Given this list of marker genes PPP2R5C (NCBI Gene Id 63377), MIR647, KTN1, ATP13A1, LINC01255, ERICH6B, ENY2, RN7SKP34, PCP4 (Purkinje cell protein 4), RNU6-1243P, CD163, EPSTI1, TNFRSF4, ENPP3, UFL1-AS1, STARD3, RPS28P1, ABHD13, KRTAP8-1, ISG15, HSPD1P7, LHPP, ZNF846, GTF2H4, SPATA7, MTCL1, MRPL48, ESPNP, NKTR, MRPL39, LINC01742, MS4A7, LINC01697, LRRN4, CYP4A27P, SNHG5, ZNFX1, BNIP3P5, SLC1A4, ELOVL1, HSPA14, ENSG00000277020 (NCBI Gene Id 105370103), TAF3, LIFR-AS1, ATP7B, FLOT1, CSPG5, CFAP61, ENSG00000260132, MAGED2, ADD1, CEP192-DT, COL15A1, MT-TE, FAM185BP, NPAT (nuclear protein, coactivator of histone transcription), RNU6ATAC34P, ZNF343, LINC01215, HABP2, CACYBPP3, SYNE2, RNA5SP29, POMGNT2, DYNLT1, SIMALR, NDUFB2-AS1, GPR137C, KANK1, TMEM123, LINC02633, TTC3, ABCD1, KCNMA1, RSPH3, PSG6, MAFTRR, EIF5A, TBRG1, SLC8B1, SCTR, RPSAP64, MT-TS2, KIZ, BTBD3, PSMA6P4, TPR, SYTL3, DAB2, MIR520B, P2RX1, PGAM3P (phosphoglycerate mutase 3, pseudogene), RPL38, RAB11FIP2 (NCBI Gene Id 22841), RNASEK-C17orf49, RB1-DT, PIK3R3, REPS1, LINC02593 (NCBI Gene Id 284598), FCF1, TTLL5, VASH1, SYT5, KIF4A, SOX6, KRTAP19-2, HES4, RUNX1, LINC01168, KCTD10, MHENCR, STRADB, ARMH1, UBAP2, TUBA1A, TEX30, FKTN-AS1, UNC79, PPP1R2P2, ICAM4, MADCAM1, MCM8-AS1, ZBED3-AS1, ATG3, ZNF225, LINC00554, EFCAB6-DT, RHOT2, ARSG, SEC23A, RHOBTB1, KEL, WDR91, USP17L18, RASSF2, INSIG1, ANAPC15, TRIM7-AS2, SPAG16-DT, KRTAP19-3, FBXL5, RANBP3, FAM217B, CENPBD1P (NCBI Gene Id 92806), ARID1B, CREB3L2, ALDH5A1, PPP1CC, SPOCD1, LINC00159, IGHV1-14, KDM1B, IFT52, ETS2-AS1, NDUFA6, TRAPPC1, CASP4, BTN2A3P, RNU6-836P, RNU6-782P, BRD2, GRAMD4, ENSG00000204684, MT-TN, MIR8075, MTND5P11, MTG2, MSMB, RALB, KRAS, LITAF, SLC35A5 (solute carrier family 35 member A5), MYOSLID-AS1, ARMC10 (armadillo repeat containing 10), LINC00865, AFDN, RWDD2B, CRYGN, DSCC1, ZNF821, EDRF1-AS1, BTF3L4, FRG1DP, MED15, PDZD11, ZC3HC1, ENSG00000260520, MYO18A, SLC7A5P2, HLCS-AS1, IKBKB-DT, FAM24B, LINC01080, SH3BGR, RTCA-AS1, C12orf75, KRTAP19-7, SH3KBP1, MTFR1, NIPSNAP1, TMEM263, RNU6-759P, RBFA, ZNF235, TRAK2, DDX39B, MAP3K7CL, SCARNA13, PRPF4, RBM11, SIDT1, CALM1, HIGD1AP14, MZB1, NPRL2, PARGP1, MRPS31P4, PPIAP11, STAT3, COX7C, AKAP7, PRCP, MIR3613, COX5AP1, ZBTB18, RBM12, MEG8, LCK, KIF26A-DT, KRTAP20-2, BID, WNT8A, GEMIN4, SLC20A2, REC8, ZCWPW1, LINC00654, RPL34, OXR1, RNF146, TMEM175, TAGAP-AS1, ARL2BPP3, HEY1, CLIC6, STRN3, OR10H5, GET1, AKR1D1, SPATS2L, NAPG, SPTAN1, ASPHD1, ATP2C2, TASP1, SETDB2, RALY, TPM2, ZNF732, KBTBD6-DT, AFG3L1P, CPT2, SAMD4B, GID8 (NCBI Gene Id 54994), SPATA2, VWA8-AS1, TBCD, NUP58, NIN, LIG1, RNA5SP21, NAE1, RTCA, MORC3, DLST, ZNF276, KAT6B, RPRD1B, TTC39A, ZSWIM9, MLEC, CUL5, VIP, HEXIM2-AS1, GNG10P1, GUCY1A1, CYP2F2P, CHMP3, SECISBP2, NHLRC3, EXD2, HBP1, GSTO2, LINC01522, ABCC9, ABCD4, LPIN3 (NCBI Gene Id 64900), THAP9, MRPL49, ZNF548, IPO5 (importin 5), DCAF5, WDR31, SNHG11, CEP295, ZSCAN25, ENSG00000267288, SAMTOR, THNSL1, LINC00189, SCN9A, EML3, LRR1, DDI2, EML1, LINC00658 (NCBI Gene Id 100507629), MAPK6P2, MRPS31P5, DAAM1, SLC35F5, TEX10, MS4A14, MGRN1, KDM5A, CPNE1, LYPD5, GLRX5, RORA-AS1, KIF13B (NCBI Gene Id 23303), CCT8, PPP1R3D, PAFAH2 (platelet activating factor acetylhydrolase 2), DCLRE1A, CIRBP, PIK3AP1, RNU6-8, LINC00710, PODN, ADAM28, MT-TP, ITIH5, AACS, ANKRD29, MARK1 (microtubule affinity regulating kinase 1), TTLL4, ZNF582-DT, MRPS17, HS6ST1, DSG1-AS1, WAC, KRTAP6-2, NUP153-AS1, ZBTB26, NUDT15 (nudix hydrolase 15), JPH4, PAIP1, ZC3H15, MRPS16P2, ZNF365, ANKRD66, PDE10A, KDM8, BRWD1, CALM3, ADISSP, ZFP69B (ZFP69 zinc finger protein B), RNU6-1257P, ARHGAP5-AS1, IFI27L1, RPS29, LATS1, FTO (NCBI Gene Id 79068), TMX4, ZNF460, GAS7, ACADL, RPL11, POU6F2-AS1, PAXBP1, WDTC1, ZNF256, SPINT1, ELP4, CCDC86, OBI1-AS1, ATXN8OS, TLR9, KCNH3, ARHGAP24, VPS16, RPL23AP12, RUBCNL, SEC13, TYMSOS, SULT1A1, IER3-AS1, PRM1, TTC3-AS1, LRRC8C-DT, POLB, TIAM1, MTRF1L, NOP14-AS1, COX20, ZNF155, LINC01134, LRRC63 (leucine rich repeat containing 63), RAC1P3, ZNF544, TONSL, LRRC8C, FEM1B, EIF5A2P1, SNORA71E, CYP46A1, DPP6, KCNK15-AS1, GNG2, SOD1, ASXL1, SEZ6L2, ZNF606, SUPT20H, DHRS4, ARNT, CORO1C, MIR7151, WARS1, METTL8, TYW1B, SON, NBPF1, CAMK2G, H2AZ1-DT, MTCO3P12, H4C16, ZFHX2-AS1, VPS13A-AS1, COA4, PPP4R3A, UQCRC2, STT3A, DHRS4-AS1, VPS13B-DT (NCBI Gene Id 124900254), ATP9A, H2AZP3, ANP32A (acidic nuclear phosphoprotein 32 family member A), MIR7111, AP4M1, LINC00921, RNY4P14, FGF14, CRYZL1, SSX2IP, ARF5, SATB1, POU6F2, HMGN1P5, WDFY2, SHISA2, H1-4, FUNDC2, WDFY4, BORCS7-ASMT, BACE2-IT1, RNF103-CHMP3, ZNF624, LINC02295, DENND6A-DT, FOS, ZNF121 (NCBI Gene Id 7675), RN7SL164P, KCNE1, C1orf174, CTR9, OLMALINC, MTA3P1, SPMIP4, SRC, SLC35F4, EIF4ENIF1 (eukaryotic translation initiation factor 4E nuclear import factor 1), KCNS1, TAF1, NARF-IT1, EFCAB14, SMARCA5, LDHAL6FP, KHDRBS2, SLC47A1, DR1, CUEDC1, PYM1, ENTPD1-AS1, ARID1A, SLFN12, SUB1, UNKL, CCDC146, VARS2, PTPRU, KRTAP19-10P, LINC01075, SETD4, PTRHD1, LEPROT, LSM14B, NUP210, C8orf74, MAP3K3, ARFGEF2 (NCBI Gene Id 10564), DNAH7, IFT88, NANOS3 (NCBI Gene Id 342977), CHD9, FBXL13, LINC00310, LST1, MT-TY, TRBV8-1, EPCIP, PIGG, GPR108, RAB30-DT, STAM2, LINC01624, SEPTIN7, PHLDB1, PRPF19-DT, CTSG, SMIM13, IFIT3, TMED5, TXNDC12, KDM1A, MOK, BAGE2, HERC3, LCP1, SHD, MYCBP2-AS1, CACNB2, SLC37A3, SFI1, LRCH1, ENKUR, GABPA, TRAM1 (NCBI Gene Id 23471), POLR1F, TMEM241, URB1-AS1, CLTA, ENSG00000179253, CNIH2, SRRD, DCHS2, LRAT, KRT26, ROM1, ATM, RPH3A, TCAF1, DNAJC3, ENPP2 (NCBI Gene Id 5168), SUSD4, VPS36, ABLIM1, APLF, LRRC61, DBT, TMEM272, CENPT, LINC01229, KIF18B, DDX50 (DExD-box helicase 50), AMZ2, SNHG31, PMS2CL, HTR5BP, ADIRF-AS1, ANAPC16, RAD51, TEX14, KAT14, TLDC2, F8, ERG, PLEKHG2, CDK5RAP3, TPMT, ZBED3, ZBTB17, LZTFL1, SERGEF, RNY3, EIF3FP1, CSNK1G2, COX4I1, ATP8A2P2, C11orf96, CNOT9, PHF8, CLEC14A, TADA2B, TMEM141, DUX4L16, DUSP5, AHI1, RNF214, RB1CC1, LRRCC1, DENND6A, LINC00299 (NCBI Gene Id 339789), PCBP1-AS1, ZGRF1, PWWP3A, SMURF2, PSMG1, HMGN1, LINC01607, MT-TH, GJE1, RNA5SP484, EXOSC8, ZNF101, ODR4, RAD1, ADCYAP1, DOP1B, CRLS1, IGHV7-34-1, SLC46A3, LINC00431, TNKS2-DT, PA2G4, MT-ND6, ZC3H14, VAC14, CCDC83 (NCBI Gene Id 220047), CFAP298-TCP10L, CYB561, KIF5C, PTPA, LINC01515, CEP135, STAM, MMP25-AS1, L3HYPDH, SPOP, RILPL1, NCAPG, SLX4, ESD, PCSK7, MSI2, ERBIN-DT, MIR4733, ZNF19, FBXO3, METTL2A, C12orf43, CEP250-AS1, GRID1, RN7SL827P, SZT2, MT-TF, C14orf93 (chromosome 14 open reading frame 93), HMGB1, ORC3, PANK1, RBM26, HPS4 (HPS4 biogenesis of lysosomal organelles complex 3 subunit 2), CCDC137, GTSF1L, HMGN1P2, TIMM23, SH2D6, CCNI, EAPP, CCDC169, CDIPT, FAM13A-AS1, SNHG15, CPB2-AS1, TUBG1, NMD3, SERTAD3-AS1, LRRFIP1, MADD, CALB2, CCDC102B, SELENOP, DUT, RETREG3, USP39, MRPS30-DT, RGS17P1, KIAA1217, ZNF16, GART (NCBI Gene Id 2618), DPY19L2P4, NUTF2, RN7SL575P, EIF2S3, KIFBP, APPL2, CDK5R2, RPS6P23, FRG1BP, SAP18, RARS2, TRADD, LMAN2L, CTRL, DDHD1, NRIP1 (NCBI Gene Id 8204), PHACTR3, PNKD, CFAP184, ANKRD20A5P, CABYR, RNU6-1107P, NGLY1, AMMECR1LP1, RN7SKP186, ZNF679 (zinc finger protein 679), IGLVIV-64, NUDCD1, SFR1, HOOK2, KIF20B, LINC02731, YPEL1, ACTN1, CSTF1, TSPAN4, TUBGCP3, NCOR2, LINC00463, TTI1, VWA3B, IFNAR1, FRG1EP, SLC4A4, CDC20, LINC02938, CRNKL1, AGK, PIAS4 (NCBI Gene Id 51675), RWDD3-DT, CROCC, ANTKMT, RPGRIP1L, DSCR4, NKILA, ZNF460-AS1 (ZNF460 antisense RNA 1), SUGT1-DT, KMT5A, MED10, RNASEK, ARHGAP40, EXTL3, ALG11, CCDC88C, KIF26A, TMEM263-DT, LIMCH1, KAT6A, COMMD6 (NCBI Gene Id 170622), RBMS1, SLCO4A1, PABPC1L, TNFRSF19, CEP95, LRRC27, GLB1, HNRNPF, RNU6-436P, GNPAT (glyceronephosphate O-acyltransferase), B3GLCT, RCVRN, G2E3P1, FAM91A1 (NCBI Gene Id 157769), RPN2, PIGP, PAPOLA-DT, IGHV3-36, CREB5, CDNF, WARS2-AS1, VAMP2, FBXW4, UBAC2 (UBA domain containing 2), HES1, CALM2P3, CYP2E1, TMEM116, INO80C, DOCK8-AS2, PCCA, LINC01864, MX1, AIRIM, CCDC169-SOHLH2, TRPM8, SPECC1, STN1, ESF1, UBE2H, KLLN, TLK1, ARHGEF7-AS1, DPM1, MIPEPP3, ZDHHC14, C10orf88B, MED23, ZC3H18, SLC31A1, MIR6813, WDR19, ADI1P1, TMEM135 (transmembrane protein 135), NOL4L, HEY2, LIPA, VANGL1, SRP54, ANKEF1, BLOC1S2, OXCT1-AS1, BTG1-DT, SDR39U1 (NCBI Gene Id 56948), RDH10, ATP1A3, GPR15LG, NAT10, DNAJC3-DT, VPS13B, MMP24OS, BDNF-AS, CLDN10-AS1, SOCS4, COPS4, PDSS1, TMEM150B, SELENBP1, TNKS2, PRORSD1P, HINT1, MIR4512, RNA5SP283, LRRC4C, SPMIP2, PDIA4, LINC02777, ENSG00000247131, SIRPD, KRBA1, DEDD, PER1, PLAGL2, DYNLL2, SNRNP40, SYNJ1, ENSG00000177596, ENSG00000228484, GOLGA7B-DT, ANTXR1, AREL1, CSNK2A2, DUX4L9, RPL12P3, RAB3IP, MTUS1, MCM8, TMEM50B, ITGA4, DCTN6-DT, STX18-AS1, CKAP2-DT, CMTM3, ZFAND4, RNU6-1234P, NSUN6, ANAPC4 (NCBI Gene Id 29945), ENSG00000229962, RWDD3, VPS26C, HEG1, IMMP1L, NLRP13, LINC02320, ELF2, SYS1, BTG1, ABI2, SLBP, PTK6, LINC02266, BRWD1P1, SIRPB2, MYH14, MT-TC, CBR1, RBM17, LINC00426, PCED1A, RNF6, SMG1P3, PTK2, LGMN, ELMO2 (engulfment and cell motility 2), XKR5, HAUS4, LINC02558, CHEK1, MFHAS1, MRPS30, HMGB1P6, OBSCN, IGHVII-30-1, NEK2P4, RN7SKP114 (NCBI Gene Id 106480868), FOXN2, CDK5RAP1, MIGA1, LEPR, ATL1, ARHGAP45, MAGT1, TIMM9P2, LTN1 (listerin E3 ubiquitin protein ligase 1), E2F3P2, CHRNA3, STX18, SNX16, UBE2H-DT, RBM22P2, MT2A, DGKD, TMEM230, FAM107B, NUDT5, SSU72-AS1, TCOF1, C20orf141, ATG4C, HCK, ACAA2, LZIC, MAP3K7, GGT1, CBFA2T2, TOX2, NEIL2, CD28, WAC-AS1, SAT1-DT, LINC00114, NRSN2, HLCS, ENSG00000212553, HERPUD1, CENPO, CAT, DNAAF2, THOC1-DT, LINC03060, WDR1, EPCIP-AS1, TPD52L2, DUSP11, ZAP70, IFNA12P, RNF103, ZFP90, WWC3, PPP5D1P, DSCR8, NDUFB8P2, MIR4536-1, ECRG4, NEURL4, CRAT, OPA3, TXNIP, LINC03028, PALD1, MIR29B2CHG (NCBI Gene Id 388732), SMG9, APMAP, ZNF672, SGIP1, OGA, ARFIP1, LSM5, RPS23P6, ADNP, SRSF5, DUX4, EEF1G, RNVU1-2, PIGH, MT-TI, THOC5, MT-TM, STK17B, SNHG32, H6PD, HTATSF1, TPT1P1, RBM47, MCF2L, PET117, CREB1, CXCL16, CMTR1, R3HDM4, SCAND1, CGRRF1 (NCBI Gene Id 378763), SLC16A12, XKR7, PNKP, LACTB2-AS1 (NCBI Gene Id 286190), PXMP2, PPP1R2P4, SPHK1 (sphingosine kinase 1), RCOR1, MROH1 (NCBI Gene Id 84500), PRPF19, ETV1, ARL2BP, DHX58, METTL13, E2F6, CDC123, SNUPN, ATP5PO, SELENOOLP, NOPCHAP1, WWP2, NOLC1, TMPRSS2, ANKRD20A11P, PHF11, RGCC, HM13, OXSM, TMEM91, ZNF260, UBN1 (NCBI Gene Id 50641), ZNF280D, ACBD6, FBXO21, SLC22A2, NUP98, FBXL3, CAPG, RNA5SP194, TAF6L, TMIGD3, PPIL4, ZNF775, SERTAD3, LIG4, ECT2L, CNOT4, TCTN1, LINC00649, MGARP, FNIP2, RBM26-AS1, PRELID3BP5, EIF4EBP1P1, SLC40A1, TGFB3, LTA4H, FAM245A (NCBI Gene Id 728218), ENSG00000282012, SNORD35B, WASH3P, ENSAP1, ADAMTS1, NINJ1, MT-ND2, ARGLU1-DT, PES1, HECTD1, PPP1R26P1, FAM177A1, RAB30, USP37, TXNDC16, SLC9A8, CBX3, IGHV2-26, HS3ST3B1, RPL39P25, IST1, MYL4, TGM5, LRRC37A6P, CDIPTOSP (CDIP transferase opposite strand, pseudogene), MUC6, CTBP2, PTGES3P3, ASCC1, SPAG16, WBP1, BARD1, NUCB2, ANKRD36B, TDRD3, TM7SF2, LINC02251, LEF1-AS1, ANLN, OTUD6B-AS1, WDHD1, PAPLN, TMPPE, WBP2, USP40, RCBTB2, ZNF217, GPR17, MT-TT, METTL21A, SEC31A, BCLAF1, RNY1P3, PIP4P1, RN7SL288P, UTP18, RNASEH2B, DLGAP5, ICAM2, TBL3, CCDC171, TMEM86A, CCDC18-AS1, DCAF17, RALA, TYMS, BRK1 (BRICK1 subunit of SCAR/WAVE actin nucleating complex), C1orf185, RPL34-DT, RHOT1P2, RPS4XP16, RNA5SP309, GCLC, ING3, TBC1D32, CERS3, CHODL, RN7SL491P, FBXO48, MAP3K8, CD248, ZNF133-AS1 (ZNF133 antisense RNA 1), ICE2, RDH12 (NCBI Gene Id 3789), RPL39, CYP2U1, SRSF6P2, TMED10, BAG3, APP-DT, B3GALT5-AS1, MYH9, OXR1-AS1, CKAP2, ATP6V0D1, PTPRK, SLC23A2, TMC6, SLC37A4, FARS2, SMAD4, TCF7L2, UBE3D (ubiquitin protein ligase E3D), SRRM1, RNF17, PTEN, DYNC1LI1, ATF6B, ZNF299P, RPS6KA5, MBTD1, PTPN3, NRXN3, MEOX1, WIPF1, DIAPH1, CD3D, TLK2, SNX19P4, TOP1MT, FAM182B, GUSBP18, TRIM9, LINC00683, ANGEL2, SOX1-OT, GMEB2, AFG2A, CD47, AZU1P1, HNRNPA2B1, DTX1, MST1, CROCCP2, NDUFA12, POGLUT3, CLN3, HACE1, CNOT10, FUOM, CNGA1, ME1, HMGB3P22, EIF2AK4, CT75, CAB39L, CFAP298, LINC00482, PSEN1, LCA5L, BTBD7, MAN1A1, CIMIP2B, GATB, DONSON, XPO7, LINC00705, WASHC4, MAP4K1, GSR, CCDC88A, RPL13AP3, ZNF225-AS1, LINC01385, VWA8, PMEPA1, BACE2, CNTROB, FAM3B, MIR4294, APOBR, USP25, ERG28, INSIG1-DT, PAFAH1B3, TMX3, ABCA4, LDLRAD4, LZTS1, HGS, SNHG10 (small nucleolar RNA host gene 10), HDHD5, MTF2, RNA5SP469 (NCBI Gene Id 100873712), FKBP4P1, GALNT11, MIR4425, RALGAPA1, ACOT11 (NCBI Gene Id 91515), DCTN6, ADIRF, DGLUCY, HLCS-IT1, DDX42, HLA-DMA, LINC02716, CDC20-DT, OPRM1, RTKN, NACA, DSE, LINC01749, ZFC3H1, ERCC1, NDC1, OPRK1, GRN, NFKB1, ARL16, GLYATL1, CIART, SYS1-DBNDD2, PAXBP1-AS1, RFC2, SORBS1, UBE4B, CALN1, PCDH8, CHKA (NCBI Gene Id 1119), NIPSNAP2, ETFBKMT, IGSF5 (NCBI Gene Id 54046), SKA3, PCBP1, SPECC1-DT, MYCBP2, SNHG22, MCMBP, TEX29, SSH2, REEP5 (NCBI Gene Id 94845), DHX40, TTC33, GOPC, HDHD5-AS1 (HDHD5 antisense RNA 1), SRP54-AS1, NDRG1, FBXO6, RNF123, ZNF280C, THAP9-AS1, EVL, ENSG00000232360, KRTAP13-6P, DNAJC8, DTX4, KIF18B-DT (NCBI Gene Id 118827817), TMOD4, ADHFE1, PRC1, ISCA2, ZNF263, SLC45A1, ALKBH2, NUDT6, COLGALT1, SYMPK, LINC01053, UQCC1, RPRD1A (regulation of nuclear pre-mRNA domain containing 1A), UBE2L3, FOXP1, CLK2, MT-TA, AGGF1P8, ATP6V0E1, ERVK3-1, LINC01140, TACC1, LRRC59, ZNF573, HUNK, SUGT1, MT-RNR1, EXTL1, RNU6-290P, TRBV8-2, ATP6V0D1-DT, DYNLT3P1, BIVM, RHOT1, LAP3, PLCXD2, POM121, EXOC3, MFSD11, TRIP10, ZNF32, MOV10, ZNF839 (zinc finger protein 839), HMGCS1, WNT2B, RNF182, CHODL-AS1, CNNM1, SLA2, MTPAP, PRKAR1A, FBXL8, MAPK1IP1L (NCBI Gene Id 93487), UFL1, RCAN1, THOC1, MRPL42, LDHC, SEPTIN9, THAP1, SCGN, RIPK1, RFC5, CRISPLD2, CEP250, TSPYL1, RPSAP1, NF1, RAD51C, VN1R87P, ELP3, NMNAT1, TUBGCP4, SNX14, LINC00540, PANK2, BRPF3, LYRM4, RBBP7, ATP5MFP1, ATP6V1D, H3-3B, RB1, AHI1-DT, IRF8, PROSER1, BCAP29, BIVM-ERCC5, ELMOD2, YAP1P1, GDPD1, KIFC3, NARF, MAP4K5, DDX39B-AS1, MALAT1, RPL7, IDI1P3, PCBD1 (pterin-4 alpha-carbinolamine dehydratase 1), BIRC3, LINC02643, SNORD48, C2orf68, H2AC10P, SLCO4A1-AS2, GRM4, LINC00598, BACH1, FARP1, RAP2A, UGGT2, ZDHHC13, MORF4L1 (mortality factor 4 like 1), ARL5B, WDR27, BRIX1, VXN, RASGEF1B, PAN3, POFUT1 (protein O-fucosyltransferase 1), ESR2, ZNF219, JKAMP, SLC17A9, ARHGAP5, ZNF283, ZHX3, PTER, APEX1, PAFAH1B2, ENSG00000215156, PANK1-AS1, TPX2, LINC00602, RN7SL542P, REEP2, MROH8, GNA15-DT, FNDC1-IT1 (NCBI Gene Id 100874312), CAPNS1, PARP2, KLHDC4, KCNG3, HSPA7, LINC02012, SNORD50B, TOGARAM1, EFCAB6, ZC3H13, SCARNA17, RFX8, RPL35P9, PPP2R2C, BLCAP, DYNLL2-DT, REPIN1, MIR99AHG, XPO6, TXLNB, MIR1302-3, ACTR3C, STRIP2, NDUFAF5, CD164, FRAT2, ITSN1, CPLANE1, STAM-DT, OSBPL5, ANTXR2, BCAP31, PPM1A, HPCAL1, CEACAM21, BAZ1A-AS1, SAT1, APP, ZNF653, GBA1, COQ6, EFTUD2, MAGEH1, SDCBP, NFYB, GALNT16-AS1, THADA, WASH2P, CELF1, SNRNP70 (NCBI Gene Id 6625), TMEM106A (NCBI Gene Id 728772), NAP1L4P3, DCUN1D5, TMX4-AS1, AAR2, PAN3-AS1, HSPA13, PLEKHA2, CHD1, SEC61A1, CASP7, LINC00437, OSGEP, ZMYM4, SEC22C, RN7SL561P, CDKN2AIPNLP3, TMPRSS15, PITRM1, DCTD, PCNPP5, ETS2, PISD, ENSG00000231597, SMAD3-AS1, LINC01535, LETM2, SND1, LINC02621, KCNE2, ACADM, SLC39A8, CCDC18, KRTAP19-5, HOTAIRM1, RAD51B, PSMC2, SLC25A30, ASPG, DSCAM, TFDP2, DLGAP4, DBIL5P, TRIM5, DGUOK, ELOVL6, AURKB, BORCS7, SLF2, USPL1, FKTN, WAKMAR2, CAP1, PPP6R3, TCF4, ZNF582 (NCBI Gene Id 147948), SMG1P2, KATNBL1P6, JAKMIP3, SERBP1P6 (SERPINE1 mRNA binding protein 1 pseudogene 6, NCBI Gene Id 100420450), DDX6, RAB11A, DDHD1-DT, SPIDR, PPP4R1L, SH3TC1, CLEC2D, ZBTB46, here is a description of the gene set: Human Gene Set: NOTCH3_TARGET_GENES from publication Yevshin I, Sharipov R, Kolmykov S, Kondrakhin Y, Kolpakov F (PMID 30445619) Genes containing one or more binding sites for (NOTCH3) in their promoter regions (TSS -1000,+100 bp) as identified by GTRD version 20.06 ChIP-seq harmonization. studied in species Homo sapiens